The following is a description of a gene set: Genes down-regulated in AtT20 cells (pituitary cancer) after treatment with LIF. Leukemia inhibitory factor (LIF) mediates the hypothalamo-pituitary-adrenal stress response. Transgenic mice overexpressing LIF in the developing pituitary have altered pituitary differentiation with expansion of corticotropes, maintenance of Rathke's cleft cysts, and suppression of all other pituitary cell types. Affymetrix GeneChips were used to identify modulators of LIF effects in corticotrope (AtT-20) and somatolactotrope (GH(3)) cells. In addition to genes known to respond to LIF in corticotrope cells, corticotrope-specific changes were also observed for genes involved in glycolysis and gluconeogenesis, transcription factors, signaling molecules, and expressed sequence tags. Two transcription factors identified, CCAAT/enhancer-binding protein beta (C/EBPbeta) and glial cell-derived neurotrophic factor (GDNF)-inducible factor (GIF), dose-dependently induced expression of the rat POMC promoter when overexpressed in AtT-20 cells. LIF further induced POMC transcription with C/EBPbeta, but not with GIF. C/EBPbeta also induced expression of the SOCS-3 promoter that was further enhanced by cotreatment with LIF. However, GIF did not affect SOCS-3 expression. These results indicate that C/EBPbeta and GIF are downstream effectors of LIF corticotrope action. LIF also stimulates the expression of inhibitors of its actions, such as SOCS-3 and SH2 domain-containing tyrosine phosphatase-1. alpha(2)-HS-glycoprotein (AHSG)/fetuin, a secreted protein that antagonizes bone TGFbeta/bone morphogenic protein signaling, was induced by LIF in a signal transducer and activator of transcription-3-dependent fashion. Pretreatment with AHSG/fetuin blocked LIF-induced expression of the POMC promoter independently of SOCS-3. Thus, using GeneChips, C/EBPbeta and GIF have been identified as novel mediators and AHSG/fetuin as an inhibitor of LIF action in corticotropes. species: Mus musculus Mouse Gene Set: ABBUD_LIF_SIGNALING_1_DN from publication Abbud RA, Kelleher R, Melmed S (PMID 14576184), and this is the list of marker genes: Lims1, Cyfip1, Bckdhb, Hk2, Enpp2, Peli1 (pellino 1), Ostf1, Foxa2, Steep1, Hoxc9, Itga6, Sytl4, Rexo2, AU021092, Gria2, Mtss2, Sucla2, Ankrd40, Efna2, Ddc, Alcam, Klrb1a, Ahnak, Arid1a, Capn9, Tspan7, Cd24a, Dcaf11